The following is a description of a gene set: Behavior that is dependent upon the sensation of a mechanical stimulus. species: Mus musculus Mouse Gene Set: GOBP_MECHANOSENSORY_BEHAVIOR, and this is the list of marker genes: Tifab, Slc1a3, Gfi1, Nrxn1, Shank3, D130043K22Rik, Neurog1 (neurogenin 1), Htt, Drd2, Nrxn2, Cntnap2, Foxp2, Etv1, Slitrk6, Stra6, Abl2, Strbp